Given this list of marker genes Btg2, Zfp36, Dusp1, Fos (FBJ osteosarcoma oncogene), Fosb, here is a description of the gene set: from publication Cui A, Huang T, Li S, Ma A, Pérez JL, Sander C, Keskin DB, Wu CJ, Fraenkel E, Hacohen N (PMID 38057668) studied in species Mus musculus Mouse Gene Set: CUI_CDC2_LTA1_B2_RESPONSE_DN Genes negatively differentially expressed in cell type: cDC2 (conventional dendritic cell type 2) upon treatment with cytokine: LT-α1/β2 in mouse lymph nodes in vivo. Cytokines mediate cell-cell communication in the immune system and represent important therapeutic targets. A myriad of studies have highlighted their central role in immune function, yet we lack a global view of the cellular responses of each immune cell type to each cytokine. To address this gap, the authors created the Immune Dictionary, a compendium of single-cell transcriptomic profiles of more than 17 immune cell types in response to each of 86 cytokines (>1,400 cytokine-cell type combinations) in mouse lymph nodes in vivo. A cytokine-centric view of the dictionary revealed that most cytokines induce highly cell-type-specific responses. For example, the inflammatory cytokine interleukin-1β induces distinct gene programmes in almost every cell type. A cell-type-centric view of the dictionary identified more than 66 cytokine-driven cellular polarization states across immune cell types, including previously uncharacterized states such as an interleukin-18-induced polyfunctional natural killer cell state.